Given this list of marker genes AGT, ARHGAP21, BBS2, FMNL2, C1orf198, TTYH1, LRP4, ANKFY1, TMOD2, AQP4, NLGN2, GPRC5B, NDRG2, GPM6B, SCD5, ZNF404, CDC42EP4, PDE4DIP, AHCYL1, PSAT1, IL17D, IMPA1, RDX, DAAM2, DYNC1LI2, GOLM2, SRI, DNER, DTNA (NCBI Gene Id 86552), RAPH1, EPB41L2, ARNT2, PDE8B, RNF141, LRIG1, TMEM47, SAMD4A, OGFRL1, PREX1, QKI, TRIL, TTYH2, HIPK2, TACC1, SLC4A4, here is a description of the gene set: Neighborhood of AQP4 studied in species Homo sapiens Human Gene Set: GCM_AQP4 Neighborhood of AQP4 aquaporin 4 in the GCM expression compendium